The following is a description of a gene set: species: Homo sapiens To gain insight into the transformation of epidermal cells into squamous carcinoma cells (SCC), we compared the response to ultraviolet B radiation (UVB) of normal human epidermal keratinocytes (NHEK) versus their transformed counterpart, SCC, using biological and molecular profiling. DNA microarray analyses (Affymetrix), approximately genes) indicated that the major group of upregulated genes in keratinocytes fall into three categories: (i). antiapoptotic and cell survival factors, including chemokines of the CXC/CC subfamilies (e.g. IL-8, GRO-1, -2, -3, SCYA20), growth factors (e.g. HB-EGF, CTGF, INSL-4), and proinflammatory mediators (e.g. COX-2, S100A9), (ii). DNA repair-related genes (e.g. GADD45, ERCC, BTG-1, Histones), and (iii). ECM proteases (MMP-1, -10). The major downregulated genes are DeltaNp63 and PUMILIO, two potential markers for the maintenance of keratinocyte stem cells. NHEK were found to be more resistant than SCC to UVB-induced apoptosis and this resistance was mainly because of the protection from cell death by secreted survival factors, since it can be transferred from NHEK to SCC cultures by the conditioned medium. Whereas the response of keratinocytes to UVB involved regulation of key checkpoint genes (p53, MDM2, p21(Cip1), DeltaNp63), as well as antiapoptotic and DNA repair-related genes - no or little regulation of these genes was observed in SCC. The effect of UVB on NHEK and SCC resulted in upregulation of 251 and genes, respectively, and downregulation of genes in NHEK and genes in SCC. To further analyse these changes, we used a novel unsupervised coupled two-way clustering method that allowed the identification of groups of genes that clearly partitioned keratinocytes from SCC, including a group of genes whose constitutive expression levels were similar before UVB. This allowed the identification of discriminating genes not otherwise revealed by simple static comparison in the absence of UVB irradiation. The implication of the changes in gene profile in keratinocytes for epithelial cancer is discussed. Human Gene Set: DAZARD_UV_RESPONSE_CLUSTER_G28 Cluster G28: genes differentially up-regulated in NHEK (normal keratinocyte) compared to SCC12B2 cells (squamous cell carcinoma) by UV-B radiation. from publication Dazard JE, Gal H, Amariglio N, Rechavi G, Domany E, Givol D (PMID 12771951), and this is the list of marker genes: CCL20, CCDC85B, CXCL8, H2AC13, GADD45A, PMAIP1, GADD45B, CITED2, CCN2, ANXA2, INSL4, H1-10, CXCL2, PTGS2, PHLDA2, TACSTD2, MT1G, CXCL3, ATF3, IER3